The following is a description of a gene set: Neighborhood of SIRT2 Human Gene Set: GCM_SIRT2 species: Homo sapiens Neighborhood of SIRT2 sirtuin (silent mating type information regulation 2 homolog) 2 (S. cerevisiae) in the GCM expression compendium, and this is the list of marker genes: SCAMP5, PDE4DIP, GOLGA7, TNK2, PLEKHB1, IL6ST (NCBI Gene Id 3572), ZNF710, C1orf198, AIDA, DDAH1, SELENOI, MYO10, PITPNC1, SCD5 (stearoyl-CoA desaturase 5), SIRT2, GABBR1, FAM219A, DYNC1H1, MFN2, TNS2, DDHD2, MYO9A (myosin IXA), ANKFY1, EFCAB14, TMEM30A, WSB1, DYNC1LI2, MAPK8IP3, KIF3B, GLTP, TMT1A, SEC14L2, UBL3, LANCL1, PEAK1, IRAG1, SNX27, RTN4, KCNJ10, MAP4K4, GORASP1, MTUS1, PREX1, FBXW11